The following is a description of a gene set: studied in species Mus musculus Genes predicted to be targets of miRBase v22 microRNA mmu_miR_20b_3p in miRDB v6.0 with MirTarget v4 prediction scores > 80 (high confidence targets). from publication Chen Y, Wang X (PMID 31504780) Mouse Gene Set: MIR_20B_3P, and this is the list of marker genes: Rasal2 (NCBI Gene Id 320357), Rmnd5a, Syncrip, Cdin1, Ttll12, Zfp696, Adam7, Cnot4, Gtf2h1, Slc7a15, Poldip2, H2-Aa, Gypc, Acod1, Jmy, Dclk1, Sirt1, Sort1, Fgf1, Laptm5, Rdh1, Kctd9, Btbd10, Atg10, Plch1, Dhx58, Otud7b, Ebf1, Rab35, Glud1, Mindy4, Dpy19l3, Rit1, Cnot2, Prrc2c, Anapc7, Hacd2, Rreb1, Cep43, Zfp516, Nfib, Zfp619, Zfp120, Cdk17, Col25a1, Fam98a, Col12a1, Lin7c, Srek1, Bcl2l11, AW146154, Asap2, Pcdh10, Recql4, Vezf1, Abhd17c, Egflam, Kcna1, Ppp4r3a, Rap2a, Rhot1, Grm5, Kif3b, Msh5, Zfp704, Yy2, Clasp2, Mbnl1, Usp32, Heyl, Ap2a2, Adamts15, Wsb1, Rab30, Rab11fip5, Aebp2, Eloc, Aldh1a1 (NCBI Gene Id 320092), Ppp6r1, Tanc2, Tnrc6b, Ergic2, Hspb7, Cep72, Hdac3, Pan3, Sufu (NCBI Gene Id 72652, SUFU negative regulator of hedgehog signaling), Kif5c, Bcorl1, Ctbp2, Rab6a, Stat1, Usp46, Phf3, Brwd3, Ccdc150, Slc40a1, Klhl23, Csrp2, Neurog1, Nme3, Zfp799, Doc2b, Fam168b, Ttc4, Mef2a, Sorcs2